The following is a description of a gene set: Any process that results in a change in state or activity of a cell or an organism (in terms of movement, secretion, enzyme production, gene expression, etc.) as a result of a vitamin E stimulus. studied in species Mus musculus Mouse Gene Set: GOBP_RESPONSE_TO_VITAMIN_E, and this is the list of marker genes: Becn1, Cat, Gstt1, Alad, Eif2ak2, Gpx1, Ada, Col1a1, Srsf2, Fkbp1b, Lep (NCBI Gene Id 16846)